Given this list of marker genes Aifm2, Aifm1, Etfdh, Prodh, Prodh2, here is a description of the gene set: Catalysis of an oxidation-reduction (redox) reaction in which a CH-NH group acts as a hydrogen or electron donor and reduces quinone or similar compound. studied in species Mus musculus Mouse Gene Set: GOMF_OXIDOREDUCTASE_ACTIVITY_ACTING_ON_THE_CH_NH_GROUP_OF_DONORS_QUINONE_OR_SIMILAR_COMPOUND_AS_ACCEPTOR